Given this list of marker genes RPS6KB1, NR4A1, BCL2, NR1H3, RARA, NR1H2, RARB, PPARG, SREBF1, MED1, ABCA1, NR1H4, RXRA, TNF, NCOA1, TGFB1, RXRB, FAM120B, THRA, THRB, VDR, NCOR2, PPARA, RARG, PPARD, RXRG (retinoid X receptor gamma), here is a description of the gene set: from publication Schaefer CF, Anthony K, Krupa S, Buchoff J, Day M, Hannay T, Buetow KH (PMID 18832364) RXR and RAR heterodimerization with other nuclear receptor species: Homo sapiens Human Gene Set: PID_RXR_VDR_PATHWAY